The following is a description of a gene set: An induration (hardening) of the skin species: Homo sapiens Human Gene Set: HP_STIFF_SKIN Stiff skin, and this is the list of marker genes: ZMPSTE24, SMAD4, LMNA, FBN1, ADA2, PSMB8, SLC29A3